The following is a description of a gene set: Mouse Gene Set: GOBP_REGULATION_OF_LOW_DENSITY_LIPOPROTEIN_PARTICLE_CLEARANCE Any process that modulates the rate, frequency or extent of low-density lipoprotein particle clearance. Low-density lipoprotein particle clearance is the process in which a low-density lipoprotein particle is removed from the blood via receptor-mediated endocytosis and its constituent parts degraded. studied in species Mus musculus, and this is the list of marker genes: Nr1h4, Cnpy2, Apoc3, Abcc8, Hnrnpk, Ldlrap1, Khsrp, Trem2, Mylip, Crp, Il19, Pcsk9, Csk, Ldlr, Anxa2